The following is a description of a gene set: Human Gene Set: NAKAMURA_METASTASIS To determine the influence of the microenvironment on changes in gene expression, we did microarray analysis on three variant lines of a human pancreatic cancer (FG, L3.3, and L3.6pl) with different metastatic potentials. The variant lines were grown in tissue culture in the subcutis (ectopic) or pancreas (orthotopic) of nude mice. Compared with tissue culture, the number of genes of which the expression was affected by the microenvironment was up-regulated in tumors growing in the subcutis and pancreas. In addition, highly metastatic L3.6pl cells growing in the pancreas expressed significantly higher levels of genes than did the L3.3 or FG variant cells. Growth of the variant lines in the subcutis did not yield similar results, indicating that the orthotopic microenvironment significantly influences gene expression in pancreatic cancer cells. These data suggest that investigations of the functional consequence of gene expression require accounting for experimental growth conditions. Genes up-regulated in highly metastatic pancreatic cancer cells. studied in species Homo sapiens from publication Nakamura T, Fidler IJ, Coombes KR (PMID 17210693), and this is the list of marker genes: SPMIP4 (NCBI Gene Id 136895), SCRN1, HPDL, MRPS6, PGK1, KRT13, DUSP3, AKAP13, GLUL, TMX4, HCLS1, DDX24, TUBB2A, LAPTM5 (lysosomal protein transmembrane 5), SOSTDC1, GGA2, FKBP10, HS3ST1 (heparan sulfate-glucosamine 3-sulfotransferase 1), NKX3-1, CMTM3, SMYD3, STX4, TOR4A, PDE10A, SDCCAG8, AXL, TUBB6, C10orf95-AS1, PLEKHG4, PCDH8 (protocadherin 8), NTRK2, PDK3, SLC12A2, MEPCE, XCL1, FOSL1, PADI3, NRN1, BLVRA, PABPC4L, DESI2, SF3B3, ETV1, SLC16A3, ACD, PRKCB, CCDC97